The following is a description of a gene set: The process in which the anatomical structure of the cerebellar Purkinje cell layer is generated and organized. The Purkinje cell layer lies just underneath the molecular layer of the cerebellar cortex. It contains the neuronal cell bodies of the Purkinje cells that are arranged side by side in a single layer. Candelabrum interneurons are vertically oriented between the Purkinje cells. Purkinje neurons are inhibitory and provide the output of the cerebellar cortex through axons that project into the white matter. Extensive dendritic trees from the Purkinje cells extend upward in a single plane into the molecular layer where they synapse with parallel fibers of granule cells. Human Gene Set: GOBP_CEREBELLAR_PURKINJE_CELL_LAYER_MORPHOGENESIS studied in species Homo sapiens, and this is the list of marker genes: LHX5, TTLL1 (NCBI Gene Id 25809), LHX1, TTC21B, SLC25A46, KIF14, GBA1, COQ8B, HERC1, ATP7A, DLL1, AGTPBP1, WHRN, CEND1, FAIM2, LDB1, SKOR2, SPTBN2, FOXP2, RORA